Given this list of marker genes TRIM69, PRDM10, CDC25C, HERC1, SH3BP2, HHATL, PTDSS1, GVQW3, PRKAB2, ESF1, LEMD3, MT1E, SAR1A, GCFC2, TMEM68, PDE4C, ADGRL1, UBL5, MIR4437, N6AMT1 (N-6 adenine-specific DNA methyltransferase 1), TGFBI, NEMP2-DT, ASB3, UBE2G2, CTXN2-AS1, RNVU1-19, AZGP1P1, MIR7973-1, NDUFB4P4, KRT18P36, TPH2, PEDS1-UBE2V1, CLCN4, REX1BD, MAD2L1-DT, OS9, KCNH6, NET1, EIF2D, RBMS3-AS3, OAS1, DNAJC11, ACAA1, TMEM179, RALY, PAWR, RNU6-369P, RNA5SP351, ARHGAP21, CYP2C8, RIPK1, RANBP3, LINC00485, ZNF329, WDR31, ZNF133, VWC2L, STAT1, DMAP1, SRMP1, LANCL1, CCPG1, LINC00929, GTF3C5, TMEM242, CTSB, ST3GAL6, GLT8D2, LINC00663, CACYBPP1, RSF1 (NCBI Gene Id 51773), SUGT1-DT, HDAC2-AS2, PAFAH2, TMEM267, TACC2, PLEKHA3, ASAP3 (NCBI Gene Id 80984), SLCO4A1-AS2, JUND, STARD10, CEBPB, FABP5P3, RN7SKP92, CDKL4, GAPDH-DT, PRKACA, HTR5A, MYO1D, BCAT2, ENSG00000260086, RND2, UBXN7, MAP7D2, HDAC2, LHFPL5, CTBS, CHGA, ARHGEF16, OIT3, RNVU1-28, ZBTB38, RNA5SP89, KNL1, STRIP1, HSP90AA1, SYNJ1, MCL1, IRF9, ZDHHC1P1, ALK, MRRF, ST18, AFG2B, KLHL7, STXBP1, MTERF2, GPR89B, LINC02866, CBFA2T3, MAP3K12, PPP2R5A, HIRA, TKT, RPS29 (NCBI Gene Id 6235), PTK2B, SLX4IP, NKAIN1, RNVU1-25, INO80B-WBP1, MIR3188, PCK2, RNU6-431P, GOLPH3L, ZNF497-AS1, APC2, ACTG1, HLA-E, AKAP13, YWHAQ, SUCLG2-DT, RPS6KC1, ARSF, ACSL4, CYB5R4, CTNNB1 (catenin beta 1), APOA2, HLTF, RGS9BP, ARHGAP31, TMEM268, NRP1, THAP12 (THAP domain containing 12), NFIB, LINC00345, EVI5, MGAT4A, FUT5, IREB2, ACSL3-AS1, C1GALT1C1, ARHGEF7, ACIN1, UMODL1, AAMDC, HEBP2, EPS8, DET1, ACSL3 (acyl-CoA synthetase long chain family member 3), IVD, ELK3, NR6A1, ASPHD1, SSBP1, CCDC25, SNORD3A, LGALS3, RNF111, ENSG00000232995, SLC39A3, KDM2B, LMAN2, FBXL12, RBBP4 (RB binding protein 4, chromatin remodeling factor), LUC7L3, ECHDC2, C11orf68, CDK5RAP1, SRP72P2, LSM4, SGK1, RSL24D1, ABAT, PHF11 (PHD finger protein 11), LRTM1, HMGN1P9, SNX30, PCLAF, EXOC2, MTBP, GRK6, ENSG00000207002, FAM53C, TFCP2, ROCK1P1, SLTM (SAFB like transcription modulator), ZNF148, LINC01964 (long intergenic non-protein coding RNA 1964), MIR7-3, SLC16A13, SPACA5, DBTP1, HMGXB4, KLK1, METAP2, HINFP, DTWD1, OGDHL, SLC25A10, ZNF280D, PGRMC2, CDH1, SNX30-DT, PXMP2, FMN1, UBE2SP2, HSPA1B, ATP5MC3, DYNLT2B, CDC42BPA, TARDBP, MT1M, PLA2G6, UTRN, EFEMP2, BIRC7, SNORD13, CADM2, BARHL1, HRH3 (histamine receptor H3), KLHDC4, BRD2, STRAP, NDUFAF5, CDKN2AIP, RBM15-AS1, GLRA1, RNY1P10 (NCBI Gene Id 106480308), FTL (ferritin light chain), SLC35C2, ZMYND11, SLC7A2, TMEM242-DT, LINC00115, NUBPL, SEZ6, VAT1, TGS1, BRAT1, GPR158, NCBP3, CENPS-CORT, CENPS, LINC01719, PCBP2, GSAP, LY6S-AS1, ZNF385C, TOP3B (NCBI Gene Id 8940), INO80B, TNFAIP8L1, ODC1-DT, ENO1, SH3BP1, TTI2, C16orf95, MGAT2, PIF1, DDC, CSNK2B, CCDC124, SERINC5, IKZF5, ACBD5, RRP7A, GSTCD, TRIP4, SUGT1 (SGT1 homolog, MIS12 kinetochore complex assembly cochaperone), RNF186 (ring finger protein 186), RBM23, AIF1, C1orf131, MOB1B, ERAP2, ALDOC, MAN2C1, RNU6-65P, TBR1, HEXIM1, KCNK12, IMPDH2, BANP, TXNL4A, MRPL40, NCBP2-AS1, TMIGD3, LDB1, PDE8A, MIEF1, LIMA1, ZNF165, ADORA3, F10, SMUG1, CDKN2AIPNL, MRPL13, RPLP2 (NCBI Gene Id 6181), PACS2, ALDH3B1, ADD3, ELMO1, ZNF846, IFITM5, SH2D4A, TRAM1, MPRIP-AS1 (MPRIP antisense RNA 1), EPHA1, CSK, LINC01629, SLC1A5, KCNQ1, MAPKAP1, SNTG1, TAF1A, CACYBP, ELOVL1, TUBGCP3, FEM1B, DDX51, TVP23B, VTRNA1-2, MT1DP, MAP3K8, ACADSB, ZFAS1, SRRM3, DDX55, RNF2, HMOX2, PFN1P1, H2BC7, SYP, RNU1-83P, RNA5SP63, PIM3, RNF14, DLEU2, RBBP6, CTNNA1-AS1, SNAP25-AS1, TLK2P2, ATP7B, SLC35A2, CPE, TOR1AIP1, CPLX2, NREP, NHSL1, DYRK3-AS1, SCGN, FAM98B, EEF1AKMT2, LYPLA2, ACTL6B, USP3, NME1-NME2, RNF213-AS1, HK2-DT, N4BP1, DHX16, ADRM1, DIO2, NAA35, RNU5E-4P, WDR36, SLC39A11, NIPA2, SNORA70, EEF1A1P47, WASH2P, CHN2, RNU5F-1, FTH1P22, C2, TAF1A-AS1, PROSER1, RNU4-2, YLPM1, DRAP1, SIAH1, GIT1, TAF6, ANKHD1, PTPRN, GPHN, TM9SF4, RN7SL346P, TRIM35, IFI30 (IFI30 lysosomal thiol reductase), MEIS2, C8A, RPL36AL, SMG1-DT, GAPDH, AOPEP, RNA5SP283, NDUFV2, DIP2B, PTPRK, PPFIBP1, RIMOC1, WDR5, CXXC5, CSNK1E, CPNE8, SUPT3H, TPT1, P2RX6 (purinergic receptor P2X 6), RPL22L1, RNU1-1, LINC01586, ENC1, DUSP19, IL1R1, SMAD5, TDG, YOD1, CLIC1, TMX3, EFCAB13-DT, ADGRB3, CTNNA1, PITX1, POU6F2-AS1 (POU6F2 antisense RNA 1), TRIM36, CYP2U1-AS1, RBSN, RN7SL1, KLB, ZNF444P1, BCAR3, MTA3, CABIN1, GUSB, FBXW8, H2AC7 (H2A clustered histone 7), RN7SL556P, TMEM14C, TMEM120A, COX20, DAPK2, ZNF56P, PLCB2-AS1, CLPB, H4C3 (H4 clustered histone 3), ST6GAL1 (ST6 beta-galactoside alpha-2,6-sialyltransferase 1), WDR59 (NCBI Gene Id 80779), ZNF805, DIPK1B, MIR7-3HG, C12orf76, NEK5, LINC02889, PPP4R3B, SMU1, NFYB, ETV3, SFT2D3, NRSN2-AS1, UGT2A3, OSBP2, AP4M1, APLF, SPON2, HAAO, CD2AP, TCF12, PPM1N, PPFIA3, RPL21P87, SLC7A5, FAM135B, ABCA9-AS1 (NCBI Gene Id 104355297), SHF (NCBI Gene Id 90525), HMGA1, MIS18A-AS1, SLC49A3, PCDHB5, INTS12, XYLB, MYO1A, C3orf52, LINC01569, UNC13A (unc-13 homolog A), C4orf46, SOX12, RN7SKP245, POU6F2, UTS2B, MAPK8IP2, RNA5SP104, SNRPB2, NCOR2, CLHC1, LMF1, TAX1BP1-AS1, CLK4, RNASE4, NUDCD3, MEOX1, RNA5SP60, MIR375, RNU6-1276P, OSGEPL1-AS1, MRPL44, DLC1, OSGEPL1, RNU6-973P, SCRT1, TRNAU1AP, CISD1, RBM18, CENPT, PXT1 (peroxisomal testis enriched protein 1), TMCC3, VDAC1 (NCBI Gene Id 7416), ZNF843, IL1RAP, KDM2B-DT, MTFP1, HTD2 (NCBI Gene Id 109729165), NDUFAF1, TAF1 (TATA-box binding protein associated factor 1), COMMD4P1, NQO1, PNPT1, PTPRS, ENSG00000224090, TRIM28, RNU5E-1, MGST2, RN7SL288P, ENDOV, HERC3, TRAK1, HS3ST2, MAPK11, SNHG12, SMAD1, CCDC69 (coiled-coil domain containing 69), SATB2, MAP3K6 (NCBI Gene Id 9064), PSMD4P1, NUF2, CYGB, EXOC3L1, JMJD1C, ADH4, ELP2, TSPAN10, MIR548H2, TIMM10B, PLOD3, PPP1R37, SPARC, R3HDML-AS1, CFTRP1, PIK3R2, CTXN2, FDFT1, GDE1, RNVU1-15, TP53I13, GPANK1, LTBP4, SNORD118, ODC1, MARCKSL1P2 (MARCKS like 1 pseudogene 2), ANKRD27, RPL24P6, KIF2A, SLC12A1, PITPNM2-AS1, AP2A2, EPB41L2, PTP4A2, RN7SL73P, C1QTNF6, DDX56, CFAP96, SYT5, KLHL7-DT, SLC9A1, YIF1A (NCBI Gene Id 10897), SRSF6, SKIDA1, TMEM101, MAST3-AS1, TMEM260, PPWD1, RPL23AP85, RANBP3-DT, SMAD3-AS1, ZBTB8OS, DGCR2, ANKRD18B, FBXO31, H6PD, ZNFX1, PTTG1IP, ID2, GOLGA8A, MIR9-3HG, RESP18, PFKFB3, PFKFB3-AS1, SNORD50B, EFHD1, LINC01863, RNU4-1, ATOSA, GRM1, CCDC88A, MIR3142HG, TBC1D2B, HEG1, LINC01128, SAP30, KIF13B (NCBI Gene Id 23303), FBLN1, RBM15, GLUL, RAB3IP, IGFBP4, MAD2L1, CHD2, PAXIP1, BCKDK, UTP11, RMRP, CHST9, MARCHF4, HTR1A, ANKRD53, GABARAPL1, NMRAL1, ACCSLP1, DBF4, LRFN3, SH2D6, LINC02614, TMOD3, GPR19, LINC00511, CHD1, DHX38, RWDD2B, NUDC, MLPH, AIDA, NPLOC4, PHF3, LARP1B, SUCLA2, EEFSEC (NCBI Gene Id 96019), EMSLR, PHLDA1, GUCY2C, TMEM219, LUC7L, TRIM67, ENSG00000273523, KCTD6, GAS7, ROR2, MAPK8IP1, UQCC6, MIR4754 (microRNA 4754), REV1, RNU6-1036P, RNF130, MAP1LC3B, METTL15, TSSK3, MTMR2, TPT1-AS1, TRIM8, LRRC71, SEC13, TMEM169, GTF3C3, LAMC1, STAT3, CDK16, EPHX1, GCKR, MCF2L, AP3B2, SCN2A, SPAG17, G3BP2, KIF5B, LACTB2-AS1, ID2-AS1, SMOC1, MAZ, HK2, KCTD20 (NCBI Gene Id 222658), ARID5B, PHLDA1-DT, ENSG00000212551, CEP164, PSMA3, ZNHIT1, FBXO48 (F-box protein 48), CITED4, USP46, PLCB2, WEE2-AS1, NLE1, EBAG9, LINC01424, FGD4, BICDL1, GMNN, SCG3, KMT2C, PHACTR4, HRCT1, PDSS1, ZNF815P, SNRPB, MIR1302-3, GCNT2, LNCATV, PYGB, FITM2, TTC23L-AS1, ACTB, MTPN (NCBI Gene Id 94351), LINC01659, PCCA, IL1B, SELENOP, SNORD12C, NPPB (natriuretic peptide B), AKAP14, KLF11, AUP1, HCFC2, STT3A, LINC01775, BTBD7, TP53I11, ID1, TNIP1, ZNF343 (NCBI Gene Id 93666), VPS13C, MTF2, TRMT10C, DNM1L, CNPY4, GPR6, MRPL39, RN7SL525P, PIM1, KIFC3, INTS5, SVOP, CNOT7, CCDC159, OVGP1, SNHG5, SUZ12P1, RN7SL363P, NR0B2, MCM7, CALCRL, MTR, LRP3, CLYBL, RN7SL211P, MTERF3, DISP3 (dispatched RND transporter family member 3), TMCC1, HES1, RNVU1-6, FRG1CP, PDE4D, CTTN-DT, MAD2L1BP, NME2, PDHA1, GRM2, ITGB5, CD2AP-DT, MXI1, ARFIP2, LINC01198, VGF, CHRNB2, ARL5AP3, RPH3A, RGS5, PYURF, RFX2, TRIM74, OSGIN1, RPL27, PDK4, SMG1, LINC02989 (long intergenic non-protein coding RNA 2989), BBS2, ZBTB25, TSEN15, PEDS1, KLHL20, SAP30-DT, PRLHR, ARID1A, PIERCE2, BROX, SCAMP5, C6orf62, DTX4, SLC16A3, ARPP19, MYBPC1, NEMP2, ODAD2P1, CFAP57 (NCBI Gene Id 171012), HSPA8, PIK3R3, NOC4L, KLHL26, PBLD, OPRM1, PDXDC1, STMN3 (NCBI Gene Id 50861), PGBD5, DRD3 (NCBI Gene Id 2111), CTDSP1, ARHGEF3, CPAMD8, RPS5, OR2T11, KCNC1, NUCB2, FAM227B, NQO1-DT, SLC9A3-AS1, UNC80, SLC22A4, DIRC3, DRAM2, CEPT1, SEZ6L2, GPR78, LINC02093, CAMK2D, TASOR, GM2A, SLC9A3-OT1, SCG5, MYG1, NUTF2, ANG, TRIM8-DT, DPRXP3, SORD, ZNF182, SERP1, CTTN, SLC2A11, RPS27A, ABL1, BSN-DT, TLR3, ASB1, BMF, RPL13A, AFP, ENSG00000273828 (NCBI Gene Id 124904917), EGFL7, EEF1A1, CYP2W1, SLC38A1, TDRD1, KCNB1, HTRA2, AAR2, MANBAL, SLC66A3, AK3P5, GBE1, RNA5SP473, ZCCHC7 (NCBI Gene Id 84186), GSTA4, LINC00649 (NCBI Gene Id 400863), EIF4EBP3, ESPN, NME1, ZNF593, AK2, PCDHGB1, SH3BP5L, TMEM181, SH3YL1, FAM151A (family with sequence similarity 151 member A), SNORA16A, ZNF707, STYXL1, ZER1, here is a description of the gene set: Genes containing one or more binding sites for (ZNF7) in their promoter regions (TSS -1000,+100 bp) as identified by GTRD version 20.06 ChIP-seq harmonization. species: Homo sapiens Human Gene Set: ZNF7_TARGET_GENES from publication Yevshin I, Sharipov R, Kolmykov S, Kondrakhin Y, Kolpakov F (PMID 30445619)